The following is a description of a gene set: The ATM protein kinase, functionally missing in patients with the human genetic disorder ataxia-telangiectasia, is a master regulator of the cellular network induced by DNA double-strand breaks. The ATM gene is also frequently mutated in sporadic cancers of lymphoid origin. Here, we applied a functional genomics approach that combined gene expression profiling and computational promoter analysis to obtain global dissection of the transcriptional response to ionizing radiation in murine lymphoid tissue. Cluster analysis revealed a prominent pattern characterizing dozens of genes whose response to irradiation was Atm-dependent. Computational analysis identified significant enrichment of the binding site signatures of NF-kappaB and p53 among promoters of these genes, pointing to the major role of these two transcription factors in mediating the Atm-dependent transcriptional response in the irradiated lymphoid tissue. Examination of the response showed that pro- and antiapoptotic signals were simultaneously induced, with the proapoptotic pathway mediated by p53 targets, and the prosurvival pathway by NF-kappaB targets. These findings further elucidate the molecular network induced by IR, point to novel putative NF-kappaB targets, and suggest a mechanistic model for cellular balancing between pro- and antiapoptotic signals induced by IR in lymphoid tissues, which has implications for cancer management. The emerging model suggests that restoring the p53-mediated apoptotic arm while blocking the NF-kappaB-mediated prosurvival arm could effectively increase the radiosensitivity of lymphoid tumors. Cluster 3: genes activated by ionizing radiation regardless of ATM status. species: Mus musculus from publication Rashi-Elkeles S, Elkon R, Weizman N, Linhart C, Amariglio N, Sternberg G, Rechavi G, Barzilai A, Shamir R, Shiloh Y (PMID 16314843) Mouse Gene Set: RASHI_RESPONSE_TO_IONIZING_RADIATION_3, and this is the list of marker genes: Trabd, Sart3, Polr2a, Fignl1, Tulp1, Xrcc1, Setd6, Micos13, Fam136a, Pcsk4, Cand1, Spr, Sh2b1, Ar, Cuedc1, Nfix, Rogdi, Taf1c, Pias3, Actb, Wwc1, Prh1, Ubap2l, Wdr45b, Tnni3, Creb1, Ylpm1, Ihh, Impa2, Akap8, Eps15, Apc, Fbrs, Sfpq, Mapk8ip3, Igkc, Ulk1, Snw1, Eif4ebp2, Acvr2b, Zfp358, Pdgfb, Abcc1, Hoxa6, Usp19, Ninj1 (NCBI Gene Id 18081), Ube2h